Given this list of marker genes ACOX1, PEX1, PNPLA2, PEX6, PEX12, ACBD5, PEX26, PEX3 (peroxisomal biogenesis factor 3), ABCD1, HSD17B4, PEX19, PEX13, PEX2, PEX11B, PEX16, PEX14, PEX5, PEX10, here is a description of the gene set: Very long chain fatty acid accumulation Human Gene Set: HP_VERY_LONG_CHAIN_FATTY_ACID_ACCUMULATION studied in species Homo sapiens